Given this list of marker genes H4c6, Ccne2, Terf2, H2bc7, Mapk14, H2bc27, Mapk9, Cdk4, Cdc23, Ets2, H1f4, Ehmt1, H4c3, Cdkn1b, H2ac22, Ep400, Anapc15 (anaphase promoting complex C subunit 15), H2ac11, H2ac20, H2ax (H2A.X variant histone), H2ac15, H2ac10, H2ac24, H4c2, Map2k3, H4c14, H1f3, H1f5, Mapk11, Ube2d1, Nbn, Terf1, Txn1, H2bc22, Ubb, H2ac13, H1f1, Ube2c, Rbbp4, Mapk7, H2bc8, Fzr1, H2ac19, Erf, Trp53, H2bc3, Ezh2 (NCBI Gene Id 14056), H2ac8, H2ac23, Cdkn2b, H4c8, H2bc13, H2bc15, Ube2s, Anapc2, H4c11, H2bc9, H2bc1, H2bc11, H4c12, Cdc26, Map2k7, Jun, Anapc10, Mapk3, Cdkn1a, H4c1, Rbbp7, Lmnb1, Ccne1, H2bc12 (H2B clustered histone 12), Mre11a, Anapc7, Rb1, Rps27a, Mapk8, H2ac1, Ccna1, Kat5, Hmga1, H2ac4, Acd, H4c17, H4c9, H2az2, H2ac12, H4c18, Map2k4, H2ac6, H4c4, Fos, Mink1, Ube2e1, Kdm6b, H2ac7, Map2k6, Mapkapk5, here is a description of the gene set: electronically inferred by orthology from the curated human pathway studied in species Mus musculus part of: Cellular responses to stress Reactome Pathway: Cellular Senescence This event has been computationally inferred from an event that has been demonstrated in another species.<p>The inference is based on the homology mapping from PANTHER. Briefly, reactions for which all involved PhysicalEntities (in input, output and catalyst) have a mapped orthologue/paralogue (for complexes at least 75% of components must have a mapping) are inferred to the other species.